The following is a description of a gene set: Genes positively correlated with memory B cell response in peripheral blood mononuclear cell in adults (50-74) after exposure to trivalent inactivated vaccine (A/California/7/09 (H1N1,), A/Perth /16/2009 (H3N2), and B/Brisbane/60/2008)., time point 3D. Comment: Association of baseline, early and late gene expression changes with peak memory B cell ELISPOT response (Day 28 - Day 0) in older individuals from publication Haralambieva IH, Ovsyannikova IG, Kennedy RB, Zimmermann MT, Grill DE, Oberg AL, Poland GA (PMID 27317456) BACKGROUND: Studies suggest that the recall-based humoral immune responses to influenza A/H1N1 originates from activated memory B cells. The aim of this study was to identify baseline, early and late blood transcriptional signatures (in peripheral blood mononuclear cells/PBMCs) associated with memory B cell response following influenza vaccination. METHODS: We used pre- and post-vaccination mRNA-Seq transcriptional profiling on samples from 159 subjects (50-74years old) following receipt of seasonal trivalent influenza vaccine containing the A/California/7/2009/H1N1-like virus, and penalized regression modeling to identify associations with influenza A/H1N1-specific memory B cell ELISPOT response after vaccination. RESULTS: Genesets and genes (p-value range 7.92E(-08) to 0.00018, q-value range 0.00019-0.039) demonstrating significant associations (of gene expression levels) with memory B cell response suggest the importance of metabolic (cholesterol and lipid metabolism-related), cell migration/adhesion, MAP kinase, NF-kB cell signaling (chemokine/cytokine signaling) and transcriptional regulation gene signatures in the development of memory B cell response after influenza vaccination. CONCLUSION: Through an unbiased transcriptome-wide profiling approach, our study identified signatures of memory B cell response following influenza vaccination, highlighting the underappreciated role of metabolic changes (among the other immune function-related events) in the regulation of influenza vaccine-induced immune memory. Human Gene Set: HARALAMBIEVA_PBMC_TIV_AGE_50_74YO_CORRELATED_WITH_MEMORY_B_CELL_RESPONSE_3DY_POSITIVE studied in species Homo sapiens, and this is the list of marker genes: ANO8, SOCS3, STK17B, H3-5, GMEB1, ELF1, FCHSD2, PLEKHM2, CCDC6, USP6NL, WASHC2C, MAP1LC3B2, TESK2, PELI1, NFKBIA